The following is a description of a gene set: electronically inferred by orthology from the curated human pathway part of: Peroxisomal lipid metabolism Reactome Pathway: Beta-oxidation of pristanoyl-CoA studied in species Mus musculus This event has been computationally inferred from an event that has been demonstrated in another species.<p>The inference is based on the homology mapping from PANTHER. Briefly, reactions for which all involved PhysicalEntities (in input, output and catalyst) have a mapped orthologue/paralogue (for complexes at least 75% of components must have a mapping) are inferred to the other species., and this is the list of marker genes: Acox3, Crot, Acox2, Amacr, Acot8, Hsd17b4